Given this list of marker genes LHX1, ALDH1A2, EMX2, SOX17, BMP4, SOX8 (NCBI Gene Id 30812), SHH, GATA3, SOX9, NFIA, RET, FOXF1, OSR1, LZTS2, SIX1, TBX18, NPHP3, PAX2, here is a description of the gene set: studied in species Homo sapiens The process whose specific outcome is the progression of the ureter over time, from its formation to the mature structure. The ureter is a muscular tube that transports urine from the kidney to the urinary bladder or from the Malpighian tubule to the hindgut. Human Gene Set: GOBP_URETER_DEVELOPMENT